Given this list of marker genes LMNA, RNU4ATAC, UROS, GATA1, UROD, ZMPSTE24, here is a description of the gene set: Human Gene Set: HP_LOSS_OF_EYELASHES Loss of eyelashes species: Homo sapiens This term refers to the loss of eyelashes that were previously present.